Given this list of marker genes Smad4 (NCBI Gene Id 28063), Sox18, Prox1, Ovol2, Acvr1, Stk4, Stk3, Angpt1, Nrg1, Kdr, Sox17, Rbpj, Notch1, here is a description of the gene set: The process whose specific outcome is the progression of the endocardium over time, from its formation to the mature structure. The endocardium is an anatomical structure comprised of an endothelium and an extracellular matrix that forms the innermost layer of tissue of the heart, and lines the heart chambers. species: Mus musculus Mouse Gene Set: GOBP_ENDOCARDIUM_DEVELOPMENT